Given this list of marker genes NDST2, CTSZ, ATP6AP2, CTSG, MME (NCBI Gene Id 4311), ACE, ACE2, REN, CPA3, ENPEP, PRCP, ANPEP, CMA1, PREP, here is a description of the gene set: studied in species Homo sapiens The process that modulates the level of any of the various angiotensinogen proteolytic products in the blood. This occurs by the proteolytic cleavage of angiotensinogen, and its proteolytic products, to create a variety of active peptide hormones, such as angiotensin I and angiotensin II, as well as through the removal of these peptides from the circulation. Human Gene Set: GOBP_REGULATION_OF_ANGIOTENSIN_LEVELS_IN_BLOOD